Given this list of marker genes Pdpk1, Them4, here is a description of the gene set: part of: PI3K Cascade This event has been computationally inferred from an event that has been demonstrated in another species.<p>The inference is based on the homology mapping from PANTHER. Briefly, reactions for which all involved PhysicalEntities (in input, output and catalyst) have a mapped orthologue/paralogue (for complexes at least 75% of components must have a mapping) are inferred to the other species. species: Mus musculus electronically inferred by orthology from the curated human pathway Reactome Pathway: Activation of AKT2